Given this list of marker genes Stmn2, Fem1b, Lztfl1, Txndc9, Mex3c, Akap10, Nfil3, Col11a1, Dok2, Zyg11b, Cdkn2b, Slc39a10, Pth, Actl6a, Rnf169, Dnajb9, Golph3, Rprd2, Cdh12, 4930426D05Rik, Col25a1, Onecut2, Clock, Rbsn, Cpd, Lrig2, Tex2, Tnfrsf23, Neurod6, Phf6, Slc22a27, Papss1, Adam10, Crym (NCBI Gene Id 12971), Med13, Slc36a1, Gria2, Ppfia1, Rapgef4, Lyrm2, Pde7a, Nol4, Kdelr1, Dzip3, Smyd4, Ndufa4, Mylk, Arl15, Lama3, Qki, Psmd11, Elf1, Vegfc, Slc22a29, Epb41l3, Kcmf1, Ankle2, Kras, Synj2bp, Cd247, Ptges3, Ddx6, Tnfrsf22, Cracdl, Il1rap, Cramp1, Trim41, Lrrc8a, Pdk3, Pxdn, Prrg1, Rab11a, Samd3, 2310030G06Rik, Gprin3, here is a description of the gene set: Mouse Gene Set: MIR_7651_5P Genes predicted to be targets of miRBase v22 microRNA mmu_miR_7651_5p in miRDB v6.0 with MirTarget v4 prediction scores > 80 (high confidence targets). species: Mus musculus from publication Chen Y, Wang X (PMID 31504780)